Given this list of marker genes PSAP, ARSA, GBA1, NEU3, GALC (galactosylceramidase), HEXB, HEXA, NEU1, NEU2, GM2A, LIPA, NPC1, SCARB2, NPC2, GLB1, NEU4, GLA, here is a description of the gene set: studied in species Homo sapiens Human Gene Set: WP_DEGRADATION_PATHWAY_OF_SPHINGOLIPIDS_INCLUDING_DISEASES Degradation pathway of sphingolipids, including diseases